The following is a description of a gene set: studied in species Mus musculus Mouse Gene Set: GOBP_HOMOPHILIC_CELL_ADHESION_VIA_PLASMA_MEMBRANE_ADHESION_MOLECULES The attachment of a plasma membrane adhesion molecule in one cell to an identical molecule in an adjacent cell., and this is the list of marker genes: Dsg4 (desmoglein 4), Amigo1, Dsg2, Clstn1, Igsf9b, Dsc2, Fat4, Cdh10, Igsf21, Pcdh10, Igsf11, Cadm2, Cdh6, Mypn, Pcdh15, Cdhr2, Emb, Cadm4, Kirrel3, Cdhr1, Hmcn2 (hemicentin 2), Igsf9, Nptn, Amigo2, Ceacam1, Cdh15, Ceacam5, Pcdhb18, Cdhr3, Robo1, Celsr3, Cdh26, Bsg, Cdh20, Cdh2, Nectin2, Pik3cb, Cdh4, Celsr2, Pcdhga4, Plxnb2, Cdh11, Cadm3, Cntn6, Pecam1, Ptprf, Cdh12, Pcdhb8, Chl1, Pcdha7, Pcdha10, Dsg1c, Pcdhgc3, Dchs1, Tenm3, Sdk2, Nrcam (NCBI Gene Id 77467), Cdh7, Dsg1a, Cdh16, Nexn, Cdh8, Dsc1, Clstn2, Pcdh18 (protocadherin 18), Prtg, Myot, Pcdha9, Cadm1, Cdh1, Pvr, Clstn3, Cdh9, Cdh3, Hmcn1, Celsr1, Ptprm, Pcdhb14, L1cam, Nectin1, Cdh24 (NCBI Gene Id 73311), Robo2, Ceacam2, Cdh5, Esam, Pcdha4, Nectin4, Dsg1b, Dscam, Pcdh20, Ptpn23, Cdh13, Cntn5, Dscaml1, Plxnb3, Pcdhb6, Palld, Pcdh8, Pcdh1, Cdh23, Ptprt, Cdh17, Ret, Dsc3, Nectin3, Pcdh12, Sdk1, Cdhr5, Fat2, Cdh22, Dsg3, Pcdh19, Fat3